The following is a description of a gene set: Phospholipases play an integral role in phagocytosis by generating essential second messengers. An early step in phagocytic signaling is the association of PIP2 and IP3 with the phagocytic cup. These are formed by the activity of phosphoinositol kinases and phospholipases. PI3K is has been shown to accumulate at phagocytic cups and converts PI (4,5)P2 to PI (3,4,5)P3. These phosphoinositides are capable of binding and increasing the activity of proteins that regulate the actin cytoskeleton. Phospholipases are lipid modifying enzymes that produce lipid mediators such as diacylglycerol (DAG), arachidonic acid (AA) and IP3. Phopsholipases PLA, PLC and PLD have been shown to be involved in antibody (IgG) mediated phagocytosis. The PLC product IP3 stimulates release of calcium from the endoplasmic reticulum. This Ca+2 concentration increase is greatest in the cytoplasm surrounding the phagocytic cup. Calcium is involved in the various stages of phagosome formation, including phagocytic ingestion and phagosome maturation. part of: Fcgamma receptor (FCGR) dependent phagocytosis studied in species Homo sapiens Reactome Pathway: Role of phospholipids in phagocytosis, and this is the list of marker genes: IGKV1-17, IGKV1-39, IGHV3-7, PRKCD, SYK, IGHV3-48, IGLV2-14, IGKV1D-16, IGKV1-33, PLD3, IGHV3-30, IGKV1-16, IGHV2-70, PIK3CB, IGLV1-40, IGHG2, FCGR3A, IGLV, IGLC7, IGKV2D-30, IGHV, IGLC6, IGLV4-3, IGLV3-27, IGLV8-61, IGHV3-11, IGLV2-8, IGHV3-13, PLD4, IGLV1-44, IGLV5-37, IGHV1-2, ITPR1, IGLV3-25, IGLV3-1, IGKV1D-12, IGLV4-60, IGLV1-36, IGLV3-16, PIK3R1, IGHG4, PLD2, PIK3R2, CD3G, IGLV1-51, IGLV6-57, IGKV1D-33 (NCBI Gene Id 652694), IGKV3-11, IGKV2D-40, IGHV3-53, PLCG2, PLPP5, IGKV2-30, IGLC3, IGKV1D-39, AHCYL1, IGHV7-81, IGLV1-47, IGLV11-55, IGHV2-5, IGKV3D-20 (NCBI Gene Id 642113), IGHV3-33, IGLV7-43, IGKC, IGKV3-15, IGLV3-22, IGHV3-9, IGLV7-46, IGHG1, IGHV1-69, IGLV4-69, IGLC1, IGLC2, IGKV5-2, IGKV1-5, IGLV3-19, IGKV3-20, PRKCE, PIK3CA, IGHV4-59, IGKV4-1, IGLV2-18, IGLV3-12, CD247, IGLV2-33, IGLV10-54, IGKV1-12, IGHV4-39, IGKV2-28, IGLV5-45, FCGR2A, IGHV4-34, PLD1, IGHV1-46, IGHG3, FCGR1A, IGLV3-21, ITPR3, IGKV2D-28, IGLV2-11, PLPP4, IGHV3-23, PLA2G6, PLCG1, IGKV2-29, IGLV2-23, ITPR2